The following is a description of a gene set: Human Gene Set: SESTO_RESPONSE_TO_UV_C1 Cluster 1: genes changed in primary keratinocytes by UVB irradiation. from publication Sesto A, Navarro M, Burslem F, Jorcano JL (PMID 11867738) UV radiation is the most important environmental skin aggressor, causing cancer and other problems. This paper reports the use of oligonucleotide microarray technology to determine changes in gene expression in human keratinocytes after UVB treatment. Examination of the effects of different doses at different times after irradiation gave a global picture of the keratinocyte response to this type of insult. Five hundred thirty-nine regulated transcripts were found and organized into nine different clusters depending on behavior patterns. Classification of these genes into 23 functional categories revealed that several biological processes are globally affected by UVB. In addition to confirming a majority up-regulation of the transcripts related to the UV-specific inflammatory and stress responses, significant increases were seen in the expression of genes involved in basal transcription, splicing, and translation as well as in the proteasome-mediated degradation category. On the other hand, those transcripts belonging to the metabolism and adhesion categories were strongly downregulated. These results demonstrate the complexity of the transcriptional profile of the UVB response, describe several cellular processes previously not known to be affected by UV irradiation, and serve as a basis for the global characterization of UV-regulated genes and pathways. studied in species Homo sapiens, and this is the list of marker genes: PIM1, DDX1, IFIT1, PIAS1, EOLA1, CRYAB, CDKN1A, SAFB, PPP2CA, UBE2G1, TM4SF1, UBE2D2, HDAC1, PSMA5 (proteasome 20S subunit alpha 5), FAM50A, PSMA6, CCN2, PSMC1, ATP1B1, CST6, SPRR2E, UBXN4, EIF4H, KRT18, TGM1, PPP2R2A, MFAP1, RAB5IF, MAP2K3, SOD2, SLC31A2, SULT2B1, SERPINB2, CAPRIN1, CSNK2A1, CNN3, LCN2, TBCC, TNFAIP3, TNIP1, SNRPA1, SPAG1, COPS8, C11orf58, HSP90AA1, IER2 (NCBI Gene Id 9592), VDAC2, NAMPT, ATP6V1B2, TJP2, UBE2I, TSG101, DUSP5, ETF1, EMP1, CCN1, PSMC6, PEA15, KCNK1, S100A7, SPRR2D, SRSF2, CSNK2B, SAA2, GSPT1, OCLNP1, GPX2, GALNT3, RNF4, GLUL, MAPK6, PSMC2, BNIP3, SPRR2A